Given this list of marker genes Khk, Tkfc, Glyctk, Aldob (aldolase B, fructose-bisphosphate), Akr1b1, here is a description of the gene set: electronically inferred by orthology from the curated human pathway studied in species Mus musculus part of: Metabolism of carbohydrates and carbohydrate derivatives This event has been computationally inferred from an event that has been demonstrated in another species.<p>The inference is based on the homology mapping from PANTHER. Briefly, reactions for which all involved PhysicalEntities (in input, output and catalyst) have a mapped orthologue/paralogue (for complexes at least 75% of components must have a mapping) are inferred to the other species. Reactome Pathway: Fructose metabolism